The following is a description of a gene set: Human Gene Set: GOBP_NEGATIVE_REGULATION_OF_BEHAVIOR studied in species Homo sapiens Any process that stops, prevents, or reduces the frequency, rate or extent of behavior, the internally coordinated responses (actions or inactions) of whole living organisms (individuals or groups) to internal or external stimuli., and this is the list of marker genes: GHRL, NPSR1, DRD2, INS, NMU, ADORA1, RETN, CRH, NPY2R, TTC21B, UCN, ARRDC3, NAPEPLD, GHSR